The following is a description of a gene set: studied in species Mus musculus Mouse Gene Set: GOMF_ACYLTRANSFERASE_ACTIVITY_ACYL_GROUPS_CONVERTED_INTO_ALKYL_ON_TRANSFER Catalysis of the transfer of an acyl group from one compound (donor) to another (acceptor), with the acyl group being converted into alkyl on transfer., and this is the list of marker genes: Acly, Hmgcs2, Csl, Hmgcs1, Clybl, Cs